The following is a description of a gene set: Human Gene Set: HP_APLASIA_OF_THE_OLFACTORY_BULB species: Homo sapiens Lack of formation (congenital absence) of the olfactory bulb. Aplasia of the olfactory bulb, and this is the list of marker genes: KIF21A, PHOX2A, ERBB3, PROK2, TUBA1A, FGFR1, PROKR2, TUBB2B, COL25A1, SEMA3A, CILK1, KIAA0586, ZSWIM6, TUBB3